The following is a description of a gene set: species: Homo sapiens Inflammatory bowel disease signaling Human Gene Set: WP_INFLAMMATORY_BOWEL_DISEASE_SIGNALING, and this is the list of marker genes: IL2RG, IL21, SMAD2, IL18RAP, IL12RB2, IFNGR1, TLR2, JUN, IL6, FOXP3, IL5 (interleukin 5), TLR5 (toll like receptor 5), STAT6 (NCBI Gene Id 6778), GATA3, IL12A, IL4R, IFNG, IL22, IL13, TGFB1, IL2 (NCBI Gene Id 3558), NFKB1, MAF, STAT3, TBX21, IL21R (interleukin 21 receptor), NFATC1, STAT4, IL23A, IL23R, IL12RB1, STAT1, HLA-DMA (NCBI Gene Id 3108), IL1A, IL10, RORA, IL17F, NOD2 (NCBI Gene Id 8135), IL4 (NCBI Gene Id 3565), TLR4, IL18, TNF (tumor necrosis factor), RORC